Given this list of marker genes IDH3G, ZNF524, DMTF1, GSTCD, PNMA6A, PLEKHH3 (NCBI Gene Id 79990), SGIP1, HAPLN1, PHF20, CALY, STAG1, SENP3, PAN2, BHLHE40, PTGR3, TAGLN2, SLC31A1, ANKRD17, CALM2, TACR1, ZBTB20, VAMP2, CXADR, HOXA3, GLYR1, KLF9, TRIM39, SGF29, NDUFA13, PTP4A1, METTL25B (NCBI Gene Id 51093), DCTN3, KLHL12, PRKACB, NTRK2, DIABLO, IFT20, WSB1, EVA1C, BLVRB, MRC2, GTF2F1, NRK, RAD51C, YTHDC1, DUSP4, DCAF11, TAOK2, NDUFA10, PSENEN, TRIB1, TAX1BP1, SLC25A25, RASGRF1, ING4, EMSY, FLT3, SELENOK, GRPR, PCSK2, ARMCX6, CABP1, STAMBP, TRAPPC1, PRPF4, PFAS, ORAI3, UFC1 (ubiquitin-fold modifier conjugating enzyme 1), CYB5D2, NDUFA4L2, YRDC, SLC39A13, DNAJB4, ZNF711 (zinc finger protein 711), LHX5, SRRM4, SUCO, RPL41, SLC18A2, VCPKMT, BCL11B, ZC3H10, KDM2A, EGR1, FBXO28, DHX36, PRPF6, AGPAT1, SPINK5, NFKB2, PPIL4, PSME3, WDR1, COL4A6, SLC25A40, FAM50A, TAFA1, ERLIN1, KCNQ5, TLNRD1, RELA, CSDE1, DNTTIP1, LINC00649, YJU2B, KNL1, TMEM59L, IRF2BPL, UBE2D3, IL6, SUMO1, ATL1, TRA2B, SPTBN4, GTF2A1, H3C1, ATP6V0C, RBM18, TCEAL9, ZFR, IKBKB, RANBP2, LTBP1, QRICH1, C1orf122, CMTR1, PAFAH1B1, HOXA9, CTC1, RAB18, PPP1R11, NMNAT2, RUSC1, PRKAR2A, PDZD7, ZNF184, UMPS (NCBI Gene Id 7372), MMGT1, DPF3, RIPK4, KISS1, MSANTD2, RAB2A, SEMA3B (semaphorin 3B), PLK4, BEX3, TSPYL5, SYNJ1, NOLC1, HNRNPH1, XPNPEP1, FAM217B, TNFSF12-TNFSF13, MRPS18B, TNFSF12, PAQR9, PDZD8, CAAP1, SF1, ATP6V0D1, GTF3C1, PTOV1, GRM3, KAT5, HOXA1, GJD2, NKX2-2, TMEM9B, MTHFD1L, ARL4D, GPR3, BAP1, BCL2L11, GRB2, ABCC1, GPBP1, KDELR2, EN2, GNL2, NMRAL1, MCAM, FHOD1 (NCBI Gene Id 29109), TAF11, JUND (NCBI Gene Id 3727), RAB3A, PLCD3, H4C5, PPP2R2A, SMIM14, RIOK1, CRH, HOXC10, GOLGA2, ZCCHC24, CCDC59, ASPHD1 (NCBI Gene Id 253982), MAFF, PITX2, R3HCC1L, CNTROB, CFAP68, MYNN, TMEM187, TMEFF1, DCUN1D4, ATF1, LRRTM1 (NCBI Gene Id 347730), ID1, JOSD1 (Josephin domain containing 1), MRPL49, ARIH1, RING1, EHD4, ZFY, TBC1D23, PKIB, ARHGAP44, MRRF, RLIM, PRKACA, CXCL16, NEUROD2, PDLIM3 (PDZ and LIM domain 3), SOAT1, PCDH10, LMTK2, SART3, TSC22D2, FOXRED1, CBX8, NAA50, MAP1LC3A, MTF1, DNAJA4, TAF10, TPT1, NOC4L, PEX11G, ANXA7, TFRC, TMEM165, WDR81, SYNGR3, EGR4, KIF1B, ATG5, CCT6B, TCEAL1, EDEM1, POLB, DST, SLC25A3, ELL2, AMD1, ATP6V1A, ARF4 (ADP ribosylation factor 4), KDELR3, MYL6, COPS2, PHLPP1, PNKD, RERE, ZEB2, ISG20L2, PTMA, HM13, SULT4A1, ADAM10, SLC30A5 (NCBI Gene Id 79021), LRP8, PDPR, PBRM1, BCL11A, FOXD3, TNFAIP1, ADRB2, FOXA1 (NCBI Gene Id 3169), AAMP, SPAG4 (NCBI Gene Id 6676), THNSL1, NTMT1, MTREX (Mtr4 exosome RNA helicase), RBP5, PHF8, RNF44, C2orf49, TMEM86A, ADNP2, SECISBP2, CHUK, DNAJC27, GMPPB, DDX51, PFDN2, CHMP1B, ERF, SKP1, ZNF516-DT, EGR2, DDX6, SSTR3, INTS12, GNB2, SPATA2L, PDP1, RELB, MARCHF6, CCNI, ANKS1A, PCIF1, GDNF, TSHZ2, CTDSP1, PPP6C, U2AF1L4, ITFG2 (integrin alpha FG-GAP repeat containing 2), ZER1, ADNP, MASTL, C1orf35, ARG2, GLOD4 (glyoxalase domain containing 4), TSPAN7, PCDH7, PSMB8, SCAMP5, VMP1, NDEL1, PDXDC1, HERPUD2, NDUFB2, CYP51A1, CCDC148, TBX20, MLF2, IL22, MAP3K10, SCG2, SOX10, BRCA2, PEPD, STT3A, RPL13A, PAK2, MBNL1, ZBTB11, CIAO1, B3GALT2, FAM76B, LINC03040, NDUFV1-DT, DOCK9, FAU, RNF40 (NCBI Gene Id 9810), NUP98, NR6A1, ALKBH5, RUSC1-AS1, PTGES3, ZBTB7A, YME1L1, CEP55, MAOA (monoamine oxidase A), RFC4, CLDN3, MLLT10, AFF4, FBXL2, DHX29, ATP6AP2, FIZ1, GGT7, SENP2 (NCBI Gene Id 59343), NR4A1, XRCC2, RETREG2, EVX1, TLE3, METTL25, PHC1, CDKN1A, UBQLN2, SEC22A, CARF, MPZL3 (myelin protein zero like 3), HMOX2, CA10, CEP57, SLC66A2, CLDN6, ADPGK, LCMT1, MORF4L2, RBBP6, UBB, ODF2, KLHL7, MYO1E, TMEM263, PCNP, ST8SIA4, PNRC1, HTN1, NR4A2, HMBS, KYAT1, CDC26, BECN1, SLC9A5, NAB2, NKX2-3 (NK2 homeobox 3), PHF7, RBMS2, LGR5, IRX6, KDELR1 (NCBI Gene Id 10945), DACT1, CDX2, ATAT1, PTPN23, CD2AP, SRSF5, MAST1, SEC24B, DDX50, MIEN1, RNF7, ARL2, CCND2, NR1H2, XBP1, IL1RAPL2, PLPBP, PRDM13, SLC34A3, TEX14, STX5, YWHAG, NOL4, CDC14B, TSSK6, SSBP3, STAT3, CUL5, CEP44, CRY2, SMARCD1, TFCP2, CREB1, AKIRIN1, UBE2H, THADA, CAGE1, PITPNM1, PHACTR3, ZNF687, TNKS2, ZZEF1, PKP4, DRD4, CTCF, TMEM243, NEUROD6, RFT1, LDAH, ENKUR, PPP1R10, TERF2, SLC25A37, GEM, RCAN1, DNAJA1, CASK, ZNF830, MAPK6, SKIDA1, NR4A3, PPP1R15A, GNB1, KAT7, TGFB2, CCN1, ISCU, HK2, SARAF, MIR22HG, SAMD10, DSG2, TFIP11, JADE1, LRRC59, GK, GPC6, SPATA7 (spermatogenesis associated 7), ELOVL5, PLK2 (NCBI Gene Id 10769), H4C8, ZMYND15, PNMA3, BCS1L, MAF, SSR4, THRA, TMEM127, VPS37B, KIAA0825, DDX3X, HS3ST3A1, EPHA2, ELK4, IFT57, OSR1, SSTR2, WDR48, EGR3, USP8, ANK2, RNF5, CHGB, WNT10A, ZNF367, C1orf43, SLC38A2, EIF5A, ORMDL3, HDX, USP2 (ubiquitin specific peptidase 2), PDE7A, NCAPH, ILRUN, COL4A5 (collagen type IV alpha 5 chain), GASAL1, CCNT1, S1PR2 (sphingosine-1-phosphate receptor 2), POLDIP3, WFDC3, NEURL1, BRAF, PRR3, KIF17, DUSP5, NR2C1, NUP42, UBA52, SLC6A4, DDX3Y, UBR5, TOMM40, KLHL1, NOS1, TSC22D3, DBF4, C6orf62, DEPDC4, RBBP8, H4C1, PAK3, NDUFV1, NIT1, TSG101, UBR4, PICK1, GNAS, CTIF, PPARGC1A, ARFGEF1, RAB7A, COQ10A, GOLGA5, FLT1, MAP3K13, MRM3, CDK2AP2, TBX5, PPM1A, OSBP, FDX1, C11orf87, NTN4, CRELD1, NAP1L2, SMARCA5, BTAF1, PPP1R3D, JUNB, CLSTN3, GRWD1, TP53INP2, RHOBTB1, LETM2, PER1, GSKIP, OGDH, DNAJC9, RCE1, SPHK2, RPRD1A, ERC1, NUFIP1, VIP, SRPRA, DUSP1, GPALPP1, TNKS, NINJ1, RAB5C, ZNF644, KCNA6, E2F5 (NCBI Gene Id 1875), ENDOV, BOD1L2 (NCBI Gene Id 284257), CHD5, GLI1, FOSB, SRSF1, NT5C3A, CCDC186, ENTPD4 (NCBI Gene Id 9583), CMSS1, ZNF23, CNPPD1 (cyclin Pas1/PHO80 domain containing 1), SMS, EIF1, NF1, TRAP1, NEK1, KCNA2, RUNDC3A, ADIPOR1, PTRH2, SERINC1, LAYN, PPP2R1A, CLDN7, PURB, G3BP2, GNL1 (G protein nucleolar 1 (putative)), CHPF, ARTN, GGA1, LCMT2, SPATA2, BEX1, YIPF6, PHOSPHO1, RBBP7 (RB binding protein 7, chromatin remodeling factor), SETX, PIAS4, GIGYF2, FKBP7, CSTF3, TRMT61B, RPL18, SALL1, FBXO8, MINK1, SLC6A15, NUBPL, ENSA, RLF, IPO11, ZCCHC9, CYSTM1, RNF141, SRGN, STXBP3, DLST, RASD1, SIK1, GALK2, GNG4, NAT14, here is a description of the gene set: Genes having at least one occurrence of the highly conserved motif M20 GTGACGY in the regions spanning 4 kb centered on their transcription starting sites. This matches the E4F1 transcription factor binding site V$E4F1_Q6 (v7.4 TRANSFAC). species: Homo sapiens Human Gene Set: GTGACGY_E4F1_Q6 Comprehensive identification of all functional elements encoded in the human genome is a fundamental need in biomedical research. Here, we present a comparative analysis of the human, mouse, rat and dog genomes to create a systematic catalogue of common regulatory motifs in promoters and 3' untranslated regions (3' UTRs). The promoter analysis yields 174 candidate motifs, including most previously known transcription-factor binding sites and 105 new motifs. The 3'-UTR analysis yields 106 motifs likely to be involved in post-transcriptional regulation. Nearly one-half are associated with microRNAs (miRNAs), leading to the discovery of many new miRNA genes and their likely target genes. Our results suggest that previous estimates of the number of human miRNA genes were low, and that miRNAs regulate at least 20% of human genes. The overall results provide a systematic view of gene regulation in the human, which will be refined as additional mammalian genomes become available. from publication Xie X, Lu J, Kulbokas EJ, Golub TR, Mootha V, Lindblad-Toh K, Lander ES, Kellis M (PMID 15735639)